The following is a description of a gene set: DCE to DNA adducts. Pathway ID: N01386. Pathway type: Env factor. Pathway class: nt06250 DNA adduct formation. Human Gene Set: KEGG_MEDICUS_ENV_FACTOR_DCE_TO_DNA_ADDUCTS Pathway Definition from KEGG: DCE -- GST -> C20304 -> C14874 == DNA studied in species Homo sapiens, and this is the list of marker genes: MGST3, GSTM3, GSTA1, GSTM4, GSTT2B, GSTT1, GSTA3, GSTA5, MGST2, GSTA4, GSTT2, GSTA2, GSTM5, GSTP1, GSTM2, GSTO2, GSTO1, MGST1, GSTM1